The following is a description of a gene set: from publication Kang HC, Kim IJ, Park JH, Shin Y, Ku JL, Jung MS, Yoo BC, Kim HK, Park JG (PMID 14734480) PURPOSE: A major obstacle in chemotherapy is treatment failure due to anticancer drug resistance. The emergence of acquired resistance results from host factors and genetic or epigenetic changes in the cancer cells. The purpose of this study was to identify differentially expressed genes associated with acquisition of resistance in human gastric cancer cells. EXPERIMENTAL DESIGN: We performed global gene expression analysis in the acquired drug-resistant gastric cancer cell lines to the commonly used drugs 5-fluorouracil, doxorubicin, and cisplatin using Affymetrix HG-U133A microarray. The gene expression patterns of 10 chemoresistant gastric cancer cell lines were compared with those of four parent cell lines using fold-change and Wilcoxon's test for data analysis. RESULTS: We identified over genes differentially expressed in 5-fluorouracil-, cisplatin-, or doxorubicin-resistant gastric cancer cell lines. Our expression analysis also identified eight multidrug resistance candidate genes that were associated with resistance to two or more of the tested chemotherapeutic agents. Among these, midkine (MDK), a heparin-binding growth factor, was overexpressed in all drug-resistant cell lines, strongly suggesting that MDK might contribute to multidrug resistance in gastric cancer cells. CONCLUSIONS: Our investigation provides comprehensive gene information associated with acquired resistance to anticancer drugs in gastric cancer cells and a basis for additional functional studies. Genes down-regulated in gastric cancer cell lines resistant to 5-fluorouracil. Human Gene Set: KANG_FLUOROURACIL_RESISTANCE_DN studied in species Homo sapiens, and this is the list of marker genes: SLC2A1, BACE2, PCK2, NFYA, LAMC2, DDIT4, FLNB, SLC43A1, ITGB4, LDLR, GOT1, MST1R, OPLAH (NCBI Gene Id 55579), CALB2, S100P, S100A14